The following is a description of a gene set: species: Homo sapiens Human Gene Set: GOBP_PURINE_CONTAINING_COMPOUND_TRANSMEMBRANE_TRANSPORT The process in which a purine-containing compound is transported across a membrane. A purine-containing compound is any compound that contains purine or a formal derivative thereof., and this is the list of marker genes: SLC25A47, SLC25A16, SLC25A51, SLC28A1, SLC29A1, SLC25A42, SLC25A4, SLC19A1, SLC35B3, AQP9, SLC25A41, LRRC8C, SLC29A2, LRRC8D, LRRC8E, SLC25A23, SLC25A53, SLC25A6, SLC29A3, SLC25A17 (solute carrier family 25 member 17), ABCC4, SLC25A52, SHOC2, SLC17A9, SLC46A2, SLC35B2, LRRC8B, SLC22A1, SLC28A2, SLC25A31, ADCY10, SLC25A26, SLC22A3, SLC25A5, SLC43A3, SLC22A2, SLC33A1, SLC25A24, LRRC8A, SLC28A3